Given this list of marker genes Egfr, Psenen, Psen1, Rps27a, Dll4, Notch3, Ubb, Wwp2, Dll1, here is a description of the gene set: studied in species Mus musculus This event has been computationally inferred from an event that has been demonstrated in another species.<p>The inference is based on the homology mapping from PANTHER. Briefly, reactions for which all involved PhysicalEntities (in input, output and catalyst) have a mapped orthologue/paralogue (for complexes at least 75% of components must have a mapping) are inferred to the other species. Reactome Pathway: NOTCH3 Activation and Transmission of Signal to the Nucleus electronically inferred by orthology from the curated human pathway part of: Signaling by NOTCH3